Given this list of marker genes Arpc2, Plcb1, Nanog, Hnf1a, Zc3h12a, Ptafr, Foxp1, Cav3, Zfp683, Nfatc4, Cdk4, Golph3, Larp1, here is a description of the gene set: studied in species Mus musculus Any process that results in a change in state or activity of a cell (in terms of movement, secretion, enzyme production, gene expression, etc.) as a result of a ether stimulus. Mouse Gene Set: GOBP_CELLULAR_RESPONSE_TO_ETHER